Given this list of marker genes TECPR2, SNN, FCGR1BP, JOSD1, NAB1, MYOZ3, NFIL3, TREML2, DSG1, ARAP3 (NCBI Gene Id 64411), PPP2R5A, GNAZ, KCNC4, NADK, MARF1, GVINP1, PDE4B, GIT2, IRF7, PI3, TAB2, LPIN2, ZXDC (ZXD family zinc finger C), FSTL3, PTPRN2, XAF1, B4GALT5, TRANK1, CATSPERB, MAK, CANT1, HEY1, IL18R1, SERPING1, GBP2, PRR7 (NCBI Gene Id 80758), BTN2A1, PADI4, ST8SIA4, EEF1D, MPZL1, BASP1, DLG3, MCTP2, FOXJ2, RUBCNL, AGMAT, GALNT10 (NCBI Gene Id 79615), CYP1A2, ANXA3, SYNE2, TSPYL2, R3HCC1L, TMCC1, MEIS2, SELPLG, CASR, ASCL3, REL, ELL, TUBA4A, TRMT9B, SEMA6A, CSGALNACT1, CTDSP2, S100P, STX3, DCLRE1C, ARHGAP45, COL5A1, SH2D3C, NMI (N-myc and STAT interactor), ABCC5, NUMB, ETS2, LAT2, BRAP, SPEN, WWC3, PTEN, SRSF5, SLC1A1, EPS15L1 (NCBI Gene Id 58513), PCBP2, PSG4, PDGFD, RALB, LRRFIP1, ZNF586, FPR2, RAB35 (NCBI Gene Id 11021), ADAM10, AKTIP, SYK, MX2, H2BC4, ADGRE2, SP140, REPS2, MAP2K3, RNF44 (ring finger protein 44), TNFAIP3, LDB1, TLK2, IPCEF1, ACAA1, VNN3P, BRD4, ALPK3, ING3, BCL3, CRLF3, ZNF44, MFAP3L, FMO1, H3C2, RARA, TUBA4B, ARHGAP35, CXCL2, CDKN2D, ZNF165, STK17B, KLF3, CFD (complement factor D), ACAD10, CD69, LMNB1, UIMC1, ENSG00000290731, KDM5A, ZNF350, RHOA, FAM184A, NFYC, FAM53C, ADM, PDLIM2, S1PR4, PCSK2, C1RL (complement C1r subcomponent like), HBB, CELF2, MLLT10, USP9X, CXCR4, RNF19B, FAM117A, AZGP1, PYGL, APOC3, GDF10, MFSD13A, FFAR2, SLC2A3, TRPV5, LINC00115 (NCBI Gene Id 93466), PKN2 (protein kinase N2), SPTLC2, RHOG, S100A14, SUSD6, RECK (NCBI Gene Id 8434), MEFV, BEGAIN, NECAP1, SLCO1C1, PPP4R3B (NCBI Gene Id 57223), ZNF473, NINJ2, R3HDM4, IMPA2, HEXIM1, DENND3, KRT37, JAK1, DAPP1, PLEKHG3, GPR12, CDH15, CDK11A, CYP4F3, CKAP4, MCL1, TNFAIP6, ATP6V0D1, CHRM3, GMIP, ZEB1, CFLAR, TMUB2, MMP25, ARPC5, RLF, FRAT2, SLC12A6, KIF5A (kinesin family member 5A), PFKFB3, here is a description of the gene set: Human Gene Set: GSE3982_DC_VS_NEUTROPHIL_DN Genes down-regulated in comparison of dendritic cells (DC) versus neutrophils. from publication Jeffrey KL, Brummer T, Rolph MS, Liu SM, Callejas NA, Grumont RJ, Gillieron C, Mackay F, Grey S, Camps M, Rommel C, Gerondakis SD, Mackay CR (PMID 16474395) studied in species Homo sapiens In the present study we used Affymetrix oligonucleotide microarrays to produce gene transcription profiles for the major leukocyte types in humans. This comprehensive dataset enabled us to not only establish which genes were expressed in each leukocyte type, but also which genes were expressed in each subset after activation. The used of a comprehensive dataset of gene profiles from all the major human leukocyte subsets enabled a novel and powerful means for identification of genes associated with single leukocyte subsets, or different immune paradigms.